The following is a description of a gene set: Abnormal nasal bone morphology studied in species Homo sapiens Human Gene Set: HP_ABNORMAL_NASAL_BONE_MORPHOLOGY An abnormality of the nasal bone, comprising the left nasal bone and the right nasal bone., and this is the list of marker genes: USH1G, PDGFRB, PPP1R12A, BRAF, CTNNB1 (NCBI Gene Id 1499), ALX4, TONSL, SIX3, SLC25A24